The following is a description of a gene set: species: Homo sapiens During normal translation termination eRF3 associates with the ribosome and then interacts with PABP bound to the polyadenylate tail of the mRNA to release the ribosome and allow a new round of translation to commence. Nonsense-mediated decay (NMD) is triggered if eRF3 at the ribosome interacts with UPF1, which may compete with PABP. An exon junction located 50-55 nt downstream of a termination codon is observed to enhance NMD.<br> Exon-junction complexes (EJCs) are deposited on the mRNA during splicing in the nucleus, remain on mRNAs after transport to the cytosol, and are dislodged by the ribosome as it progresses along the mRNA during the pioneer round of translation. EJCs contain the core factors eIF4A-III, Magoh-Y14, and CASC3 as well as the peripheral factors RNPS1, UPF2, and UPF3. UPF2 and UPF3 recruit UPF1 to eRF3 at the terminating ribosome. Thus an EJC downstream of a termination codon will not have been dislodged during translation and will recruit UPF1, triggering NMD.<br>UPF1 is believed to form a complex containing SMG1, SMG8, and SMG9. In the key regulatory step of NMD SMG1 phosphorylates UPF1. The phosphorylated UPF1 then recruits either SMG6 or SMG5 and SMG7. SMG6 is itself an endoribonuclease that cleaves the mRNA. SMG5 and SMG7 do not have endoribonuclease activty, but are thought to recruit ribonucleases. Nonsense-mediated decay has been observed to involve deadenlyation, decapping, and both 5' to 3' and 3' to 5' exonuclease activities, but the exact degradative pathways taken by a given mRNA are not yet known.<br>UPF1 also plays roles in Staufen-mediated decay, histone mRNA decay, telomere maintenance, genome integrity, and may play a role in normal termination of translation. Reactome Pathway: Nonsense Mediated Decay (NMD) enhanced by the Exon Junction Complex (EJC) part of: Nonsense-Mediated Decay (NMD), and this is the list of marker genes: SMG7, RPS23, RPL18A, RPS6, SMG8, MAGOH, PNRC2, UPF1, RPL24, PPP2CA, RPS19, RPL39, RPSA, RPL41, RPL35, RPL36, NCBP2, RPLP0 (NCBI Gene Id 6175), RPS11 (NCBI Gene Id 6205), RPL27A, RPL7A, 28S rRNA, RPS18, RPL27, RPL5, RPL22L1, RPL32, RPS5, RNPS1, EIF4A3 (NCBI Gene Id 9775), 5S rRNA, GSPT1, RPL28, UPF3B (UPF3B regulator of nonsense mediated mRNA decay), RPL23, RPL36AL, RPS21, RBM8A, UPF2, RPL38, UBA52, RPS28, RPS7 (NCBI Gene Id 6201), CASC3, RPL9, RPL29, RPL34 (ribosomal protein L34), RPS9, RPL4, RPS4Y1, RPS16, RPL14, RPL8, RPL35A, RPS15A, RPS14, RPL3, RPL22, RPL12, SMG9, PABPC1, 18S rRNA, RPS17, RPL13A, RPL21, RPS4X, RPL31, RPL7, RPS24, RPLP1, RPL23A (ribosomal protein L23a), RPL39L, PPP2R2A, RPL15, RPS10, RPL10L, RPS13, SMG5, RPS2, RPL10, RPL17, RPL37, RPS29, SMG6, RPS20, RPL26L1, RPL36A, RPL3L, RPL18, MAGOHB, RPS12, DCP1A, 5.8S rRNA, RPL37A, RPL10A, RPS26, SMG1, RPS25, NCBP1, RPS15, RPS8, RPL19, EIF4G1, RPL6, RPL13, FAU, RPLP2, RPS27L, GSPT2, RPL26, RPS3, RPL30, UPF3A, RPL11, RPS3A, RPS27A, RPS27, PPP2R1A, ETF1, RPS4Y2